The following is a description of a gene set: studied in species Mus musculus Human Gene Set: MILI_PSEUDOPODIA_CHEMOTAXIS_UP Transcripts enriched in pseudopodia of NIH/3T3 cells (fibroblast) in response to the chemotactic migration stimulus by lysophosphatidic acid (LPA). from publication Mili S, Moissoglu K, Macara IG (PMID 18451862) RNA localization is important for the establishment and maintenance of polarity in multiple cell types. Localized RNAs are usually transported along microtubules or actin filaments and become anchored at their destination to some underlying subcellular structure. Retention commonly involves actin or actin-associated proteins, although cytokeratin filaments and dynein anchor certain RNAs. RNA localization is important for diverse processes ranging from cell fate determination to synaptic plasticity; however, so far there have been few comprehensive studies of localized RNAs in mammalian cells. Here we have addressed this issue, focusing on migrating fibroblasts that polarize to form a leading edge and a tail in a process that involves asymmetric distribution of RNAs. We used a fractionation scheme combined with microarrays to identify, on a genome-wide scale, RNAs that localize in protruding pseudopodia of mouse fibroblasts in response to migratory stimuli. We find that a diverse group of RNAs accumulates in such pseudopodial protrusions. Through their 3' untranslated regions these transcripts are anchored in granules concentrated at the plus ends of detyrosinated microtubules. RNAs in the granules associate with the adenomatous polyposis coli (APC) tumour suppressor and the fragile X mental retardation protein (FMRP). APC is required for the accumulation of transcripts in protrusions. Our results suggest a new type of RNA anchoring mechanism as well as a new, unanticipated function for APC in localizing RNAs., and this is the list of marker genes: GXYLT1, TRIM5, APC, DYNLL2, VCPIP1, UPF3A, RASSF3, MATR3, FBXO32, PALLD, ZNF136, HTATSF1, CPLX2, PHLDB2, PDAP1, SEPTIN7, COA5, HMGN5, AMMECR1, INPP1, NAA50, MAP1B, BMI1, KLHL12, DCAF5, ZBTB12, HNRNPA3, ZEB2, KIF5B, ANKRD11, CCNG1, PPFIA1, ANP32B, ZEB1, CCND2, TRAK2, IFT25, MTPN, C1orf216, RFLNB, MFF, MAP2K7, LZTS3, AKAP12, XAF1, IGIP, SAMD4A, NAP1L1, NBEAL1, RBIS, BBIP1, EIF2A, CENPB, DKC1, GAB2, SH3PXD2A, CCDC34, CYB5R3, EIF3E, ATF5, CMC1, EIF3A, GOLGA4, EIF2S2, DYNLT3, APOBR, KCTD10, PGGT1B, COX20, KIF1C, SH3BGRL, SYCP3, DDR2, GLTP, KANK2, NCL, ABRACL, TP53INP2, PKN1, RGS20, SSB, RAB13, PKP4, SCAPER